The following is a description of a gene set: Human Gene Set: NF1_Q6 Genes having at least one occurrence of the motif NNTTGGCNNNNNNCCNNN in the regions spanning 4 kb centered on their transcription starting sites. This matches the NF1 transcription factor binding site V$NF1_Q6 (v7.4 TRANSFAC). studied in species Homo sapiens, and this is the list of marker genes: SLC2A4, MTX1, BMP6, JPH4, PLAAT1, ALDOC, SALL1, RBP5, SETD7, MFN1, ADAMTSL1, SSBP2, PDZRN4, CITED2, PNKP, CCN1, TMEM126B, PCDHGC3, NRXN2, SP7, CCN5, ATP8B3, ATG12, ACVR1, IMMP2L, DLX3, PRKAR2A, BDNF, SAMD12, ENO3, MACIR, NFKBIA, RPE65, GCM1, PGF, RPS6KA5, SYT9, LRRC59, TUFT1, SLITRK6, CACNA1C, SUPT3H, STARD3, SOX4, NUDCD1, CHRD, LOXL1, STAG1, SNX15, CACNB3, TGIF2, HMGN2, CALM2, SLC35G2, PATL1, IL11RA, PTGDS, RBFOX2, KMT2E, CIPC, SAMM50, DUSP10, RERE, WBP1L, HOXA9, GDPD2, SCUBE2, KRTCAP2, KLHDC8B, ACTG2, MAGEL2, WDPCP, FGF11, NKX2-2, STON2, CLEC3A, OSBPL7, CLSTN3, AFF4, CHMP2B, SLC26A7, JAZF1, TRMT2A, NFIA, METTL26, RANBP1, RNF25, IFNK, HEY1, CCDC140, SOX2, CAMTA2, SYTL2, CD63, VCAM1, NFATC3, ASPN, RCOR2, IRF2BPL, GARIN1B, B2M, BTBD3, LINC00474, RUSC1-AS1, FGF4, TNNI1, KATNAL2, ANKRD28, SIX5, GJA3, ZNF148, WDR81, CBFA2T2, KRT4, TMEM192, MAN2A1, ETV4, RMND5A, SRGAP2, REM2, KLHL2, ALK, EBF2, MBNL2, ABHD17B, FGF17, EFNB1, C9orf85, COL11A2, ERF, TMEM229B, SEMA3C, CSRNP1, RUNX1, JUP, BPIFA2, EIF4EBP3, ANKRD39, CHGA, ZNF384, LAMB3, TNXB, FERD3L, SYT8 (NCBI Gene Id 90019), SLC38A3, ASCL2, HOXC4, SEMA4C, YBX1, PPM1D, TLX3, MPP2, THBS3, TYR, TP63, CITED4, KLHDC7A, LGR6, BAHD1, ZNF768, MYLK2, EFCAB3, MGAT4A, DDIT4L, CFI, KCNH2, EXOC6, HBP1, EXTL3, ZNF423, SLC15A2, CLDN10, DLG3, MYCL, XPR1, FAM193B, TANK, NOX3, RARB, EXOSC2, WDR31, MCAM, STC1, VEGFD, TEK, NOL4, SLC24A4, STMN4, PIPOX, MEF2C, PTH1R, TARBP2, IGSF8, C10orf71, ARCN1, CALM1, RSKR, PAX3, MGST1, MOV10, ORMDL3, ZNF462, RALGPS2, GBA2, RRAS, IRS4, EPHB2, ZMYM2, GOT1, SLCO2A1, ANGPT1, CAMP, LPCAT3, ZNF436-AS1, SOAT1, ATP11C, CYB5R3, PTPN21, ZCCHC3, ALDH3B1, LAMB2, STAT3, HMGA2, AP3S1, AGR2, LINC01931, RAPGEF5, KLF13, ADORA1, RBP2, WNT16, LRRTM1, STK36, MTSS1, PAG1, MNT, MIR22HG, NTNG2, SESN3 (NCBI Gene Id 143686), RBBP4, NTRK3, NAV2, NLGN3, SESN2, BCL11A, TRIM46, SIK1, B3GALT2, SLC4A10, SOBP, MBNL1, DCT, GDPD5, GSE1, H1-0, GPR173, MID1, APLN, CACNB1, ZBTB8OS, RETNLB, ZNF436, HIP1, AAK1, TXLNGY, TREX2, ZBTB5, MDGA2, OVOL2, HIPK1